Given this list of marker genes NR1H2, SLC27A1 (NCBI Gene Id 376497), FBXW7, CNEP1R1, SIRT1, MIR548P, MFSD2A, TMX1, PLIN5, THRSP, MIR29B1, KAT5, LDLR, CTDNEP1, GPLD1, SCARB1, MIR30C1, C3, SREBF1, DGAT2, NR1H3, SIK1, here is a description of the gene set: Human Gene Set: GOBP_REGULATION_OF_TRIGLYCERIDE_BIOSYNTHETIC_PROCESS Any process that modulates the rate, frequency, or extent of triglyceride biosynthesis. Triglyceride biosynthesis is the collection of chemical reactions and pathways resulting in the formation of triglyceride, any triester of glycerol. species: Homo sapiens